The following is a description of a gene set: species: Mus musculus from publication Chen Y, Wang X (PMID 31504780) Mouse Gene Set: MIR_3083_5P Genes predicted to be targets of miRBase v22 microRNA mmu_miR_3083_5p in miRDB v6.0 with MirTarget v4 prediction scores > 80 (high confidence targets)., and this is the list of marker genes: Hectd1, Fam53b, Adgrl1, Prdm2, Hsd11b2, Trabd2b, Agl, Mllt6, Zfp775, Ccl19, Mnt, Foxk1, Fut4, Wwp1, Shisa7, Adcy1, Kcnk6, Cdyl2, Kcnip3, Smarcd1, Dmd, Morn4, Tbc1d20, Nap1l4, Ulk1, Sp1, Txndc9, Mmrn2, Pcdhga12, Chad, Hspb6, Zfp41, Pcdh15, Slco2b1, Neurog1, Ttyh3, Nfic, Rere, Cplx2, Mapkbp1, Gpc1, Ube2d2b, Tpcn1, H13, Llgl1, Cuedc1, Dnajb5, Ppp1r7, Pex19, Tmem104, Rspry1, Zfp219, Sh3gl1, Gga1, Flna, Tbc1d16, Ascc2, Ppp2r2a, Zfp395, Nfib, Bend3, Fezf2, Shroom4, Bsn, Mcl1, Chmp1a, Eng, Slc44a2, Pacs1, Eif4a1, Sh2b1, Pitpnm2, St6galnac6, Bach2, Rfng, Ptpra, Castor2, Kpna6 (karyopherin subunit alpha 6), Mal, Mknk2 (NCBI Gene Id 80551), Neurl1a, Usb1, Gnao1, Meis2, Ndst1, Clvs1 (NCBI Gene Id 93777), Ddx19b, Rab15, Naa40, Bbc3, Mlst8, Pappa2, Drg2, Rpgrip1l, Car4 (carbonic anhydrase 4), Diaph1, Btrc, Hspg2 (perlecan (heparan sulfate proteoglycan 2)), Crtc1, Ndor1, Pm20d1, Akap11, Abr, Rab11fip1, Acvr1, N4bp1, Nnat, Dusp7, Doc2a, Hmga1, Csk, Nfix, Ephb2, Fbxo46, Mob3c, Lmf2 (lipase maturation factor 2), Smpd3, Bid, Psd3, Tsku, Marcksl1, Sarm1 (sterile alpha and HEAT/Armadillo motif containing 1), Prx, Kcnj6 (NCBI Gene Id 547288), Cd247, Slc45a3, D430041D05Rik, Tmem150a, Ankrd54, Zc3h3, Asic1, Clock, Slc37a1, Ppp3r1, Ly6c1, Ubr5, Cbfa2t3, Kcne4, Atp5f1d, Rapgef1, Pde4d, Celf5, Flrt1, Arc, Stk40, Dagla, Hrnr, Dhcr24, Nfam1, Dmpk, Ppme1, Fam163b, Mtif2, Wdr11, Gm2a, Vps37c (vacuolar protein sorting 37C), Shank2, Rassf4, Cdyl, Gsta3, Grk2, Ucp2, Mpeg1, Epsti1, Smim1, Aak1, Fntb, Rabl6, Kcnk3, Nat8l, Dennd1a, Endov, Zfp385b, Car7, Slc48a1, Rad23a, Samd4b